The following is a description of a gene set: Mouse thymocytes can be classified into four major subsets based on expression of CD4 and CD8 co-receptors. CD4-CD8- (double negative, DN) cells become CD4+CD8+ (double positive, DP) cells following productive T cell receptor (TCR) beta chain rearrangement. A small proportion of DP cells are selected through interaction of clonal TCRalpha/beta and MHC self peptide complex expressed on thymic stromal cells. DP cell expressing MHC class I-restricted TCR become CD4-CD8+ cells, which will finally differentiate into cytotoxic T cells, while MHC class II restricted selection generates CD4+CD8- helper lineage T cells. We used microarrays to identify genes important for thymocyte differentiation and lineage determination by profiling gene expression in different thymocyte subsets. Genes down-regulated in comparison of CD4+ CD8+ thymocytes versus CD4- CD8+ thymocytes. species: Homo sapiens Human Gene Set: GSE31082_DP_VS_CD4_SP_THYMOCYTE_DN from publication Egawa T, Littman DR (PMID 21873191), and this is the list of marker genes: IRAK1, KIAA0040, TMEM50B, TMC6, MED22, USP42 (ubiquitin specific peptidase 42), AKT3, DHRS7, ENO3, TAP1, SELL, C1orf21, TXNRD2, TMX2, RCBTB1, SNAP47, ACTN1, ABHD5, LRRC8A, HLA-G, SNHG6, RIMS3, VSIG4, SWSAP1, PANX1, GBP4, NR4A1, CTSC, FOXN3, SPN, MKNK2, LAD1, CCDC90B, XRCC5, RGS10, PRKAA1, TSPAN9, RPN2, MADD, NAA25, CBX4, CYRIA, PEA15, TSPYL2 (NCBI Gene Id 64061), ARL6IP5, TNIP2, CRIPTO, SH3BP5, CA12, KHNYN, PARP9, ZNF281, LRPPRC, SMC6, RUNX3, IL17RB, NOP16, RPS21, HECTD2, GPR26, NFE2L2, NT5C3A, SNAPC1, MAPK8IP2, PGAP6, TMEM65, AGRN, PVT1, EIF2AK2, ARHGEF10, SRI, PTGER2, CSTF2T, RNH1, TPD52, CCR6, NADK, PTK2B, TSSK3, TRIM26, ATP5MC1, COX18, SEC61A1, HSD11B1, FASN, UTP14A, RERE, TMA16, SLC46A3, AKAP13, ABI2, KRTAP4-12, SLC30A7, HERC6, CCDC9 (NCBI Gene Id 26093), TP53, GPR155, SAMD9L, TMOD3, NINJ2, RCC1L, BATF, NOTCH2, MIF, GTPBP4 (NCBI Gene Id 23560), PABPC4, RPL37, RTF1, TMEM31, LITAF, GABRR2, TNIK, DAAM1, HIVEP3, MFSD5, RPS23, DPH5, TBL1X, TRIM5, RPL22L1, FBXW8, NAT10, ALS2CL, EGR1, NCMAP, RP1, POLR3E, XKR8, SLC2A4RG, NT5E, TMEM53, RRP12, KCNAB2, TIMP2, SLC25A24, UTP4, PTPN18, NDFIP1, SLC36A4, CTSB, POLR3D, SNRK, NWD1, PLAAT3, HLA-DRB1, PTPN12, GMIP, THUMPD3, RRS1, JAK2, POLD4, CYP20A1, RRAS, KLHL18, SIRPA, MAPK3, NUP210, CCDC88C (NCBI Gene Id 57641), SLC25A12, CEBPZOS, FILIP1L, PTGER4 (NCBI Gene Id 5734), LGALS3BP, HLCS, POLR1C, CAPZB, SPEF2, ZHX2, SEMA4A, UBE2W, ISG20, GID8, RABEPK, TRIM14, FRMD8, FAM162A, KRI1, F2RL1, PARP3, SWAP70, KIF1B, MAP2K1, RASAL3, ATP8A1, ITM2C (NCBI Gene Id 9523), SLC26A6, NTAQ1, DSE, ARHGEF18, NHP2, WARS1, MYD88, FBXO33, ENTREP2, ABHD2, UBE2J1, ICAM1, MAPKAPK3 (MAPK activated protein kinase 3), NKRF